The following is a description of a gene set: Mouse Gene Set: GOBP_VASOCONSTRICTION studied in species Mus musculus A decrease in the diameter of blood vessels, especially arteries, due to constriction of smooth muscle cells that line the vessels, and usually causing an increase in blood pressure., and this is the list of marker genes: Nos1, Svep1, Per2, Map2k1, Chga, Ahr, Bmpr2, Trpm4, Hif1a, Asic2, Dock5, Avpr1b (NCBI Gene Id 26361), Drd1, Shc1 (src homology 2 domain-containing transforming protein C1), Cacna1c, Grip2, Comp, Tbxas1, Faah, Dbh, Tacr1, Htr1b, Chrm3, Hrh1, Kcna5, Fgg, Mtnr1b, Zdhhc21, Hmgcr, Uts2r, Add3, Cysltr1 (cysteinyl leukotriene receptor 1), Htr7, Ednra, Wdr35, Agt, Grk2, Ace, Itga4, Atp1a2, Hrh2, Mgll, Adra1a, Abl1, Bbs2, Bdkrb2, Icam1, Fga, Scnn1b, Egfr, Tbxa2r, Mmp2, Htr2b, Ednrb, Smtnl1, Apln, Agtr1a, Htr2a, Alox5, Edn3, Crp, Npy1r, Oxtr, Adra2c, Rap1gds1, Cyp2j5, Edn2, Adra2a, Agtr1b, Ptgs2, Smpd3, Adm, Htr1a, Arhgap42, Avpr2, Pde5a, Cx3cl1, Edn1, Acta2, Gja5, Adra1d, Htr1d, Adra2b, P2rx1, Manf, G6pdx, Itgb1, Slc6a4, Htr2c, Lep (leptin), Adra1b, Ptger3, Ptgs1, Atp2b1, Smad6, Gja1, Itga9, Dock4, Rbfox2, Akt1, Snta1, Mkks, Casr, Rhoa, Slc8a1, Dusp5, Stub1, Fgb, Drd5, Avp (NCBI Gene Id 11998), Cacna1g, F2r, Cav1, Pdgfb, Cd38, Avpr1a